The following is a description of a gene set: species: Homo sapiens Human Gene Set: REACTOME_FORMATION_OF_WDR5_CONTAINING_HISTONE_MODIFYING_COMPLEXES Formation of WDR5-containing histone-modifying complexes, and this is the list of marker genes: SETD1A, PSIP1, YEATS2, SETD1B, DR1, MCRS1, MBIP, BOD1, KMT2B, TASP1, KAT2A, WDR5, KAT14, CXXC1, KMT2C, KANSL1, KDM6A, PAXIP1, TADA3, PAGR1, HCFC1, HCFC2, BOD1L1, OGT, WDR82, KANSL2, AKAP8L, PHF20, KANSL3, MEN1, PHF20L1, TADA2A, ZZZ3, NCOA6, DPY30, KMT2D, ASH2L, RBBP5, KAT2B, SGF29, KAT8, KMT2A